Given this list of marker genes Slain2, Rgmb, Chmp4c, Dcaf8, Nckap5, Tfb2m, Fbxo28, Pcsk5, Fyco1, Zbtb9, Trpv6, Plekha3, Tmem123, Foxj3, Tppp, Crybg3, Rb1cc1, Zdhhc8, Xrn1, Dock4, Nedd4l, Wdfy3, 2510009E07Rik, Zfp827, Rap2c, St8sia2, Rasgrf2 (NCBI Gene Id 70739), Unc80, Bahd1, Creb1, Cfl2, Fat2, Vash2, Mkrn1, Fnbp1l, Prr14l, Frmd6, Akt3, Dennd10, Tph1, Srcin1, Rgma (NCBI Gene Id 244058), Sall3, Cmpk1, Slc18a2, Cald1, Lrp8, Armc8, Camk2n2, Dcbld2, Cast, Rundc1, Irf9, Fam117b, Strip2, C2cd2, Ago1, Ptpn3, Zbtb18, Lima1, Phip, Kif23, Tanc2, Cnot7, Zfp236, Ano5, Ezh1, Fastk, Laptm4a, Trim36, Cnot6l, Elk3, Rb1 (RB transcriptional corepressor 1), Crk, F3, Usp46, Mcl1, Kcnb1, Rab12, Mylip, Rhoc, Mosmo, Neurog2 (neurogenin 2), Napepld, Tnks1bp1, Mtmr3, Pgm2l1, Stk11, Pkd2l2, Scn1a, Celsr2, Igsf10, Rnf128, Mospd2, Pde3b, Afg1l, Prrg1, Bnip2, Slc40a1, Hook3, Olfm1, Heg1 (NCBI Gene Id 77446), Wfs1, Gab1, Cc2d1a, Creb5, Snx16, Ldlrap1, Sos1, Kdm2a, Septin2, Aak1, Lypd6, Purb, Sobp, Pfkp, Map3k12, Npat, Gpc6, Neurog3, Tmcc3, Il25 (NCBI Gene Id 140806), Zhx2, Pcdha11, Rcan3, M6pr, Usp24, Pdcd1lg2, Eri1, Rab11fip5, Abcg4, E2f1, Pcdha10, Pdgfra, Cdca7, Ssh2, Fzd3, Sybu, Atl3, Cd69, Rasl11b, Gbf1, Atad2, Mfn2 (NCBI Gene Id 170731), Tle4, Mmp24, Rgs17, Rnf150, Klhl28, Vldlr, Arhgap26, Sema4b, Zc3h12c, Osm, Pcdha12, Slc6a9, Fcho2, Zbtb4, Rock2, Ogfod2, Slc17a8, Has2, Fam219b, Nagk, Rab22a, Uri1, Pitpna, Kif3b, Spopl, Cdc37l1, Agfg2, Rab10 (RAB10, member RAS oncogene family), Pcdha7, Socs6, Rapgefl1, Fbxo21, Pgbd5, Kmt2b, Tbc1d12, Rab5b, Snx8, Gramd1a, Tasor, Timp2, Wasf1, Fndc3b, Ahrr (aryl-hydrocarbon receptor repressor), Srgap1, Arhgap35, Zdhhc1, Med12l, Mink1, Retreg3, Rp2, Luzp1, Nbea, Gxylt1, D030056L22Rik (NCBI Gene Id 277265), Lrch1, Nr4a3, Klf9, Psd, Ndel1, Ano3, Idua, Pcdha3, Ankib1, Clock (clock circadian regulator), Pcdha9, Abhd5, Gid4, Unkl, Zfp148, Midn, Pxk, Nabp1, Tspan9, Pls1, Pnpla1, Pcdha4, Bnc2, Txnip, Slc49a4, Trappc14 (NCBI Gene Id 231807), Arhgef10, Atg14, Slc2a4, St6galnac3, Atxn1l, Dab2, Rps6ka4, Sorl1, Nr2c2 (nuclear receptor subfamily 2, group C, member 2), Tsg101, S1pr1, Zfp91, Chd9, Mapk4, Arhgap12, Pcdha2 (NCBI Gene Id 353234), Mfap3l, Csnk1g1, Pkd1, Arhgef11, Sfmbt1, Glis3, Rnf2, Dusp2, Lrrc55, Col4a4, Cep57, Slc17a7 (NCBI Gene Id 72961), Tgfbr2, Trappc2, Vangl1, Col19a1 (collagen, type XIX, alpha 1), Ddhd2, Lhx6, Dpysl2, Tnfrsf21, Topors, Zfand4, Map7, Myt1l (NCBI Gene Id 73066), Pcdha5, Csrnp3, Ptchd4, Pcdhac2, Slc24a2, Fbxl5, Rps6ka5, Dnal1, Sall1 (spalt like transcription factor 1), Ahnak, Marchf8, Tafa1, Ankrd17, U2surp (U2 snRNP-associated SURP domain containing), Nek9, Rest, Abca1, Jpt1, Kpna2, Usp32, Dsg4, Tmem64, Map3k13, Acer2, Mex3d, Kat2b, Pcdha8, Mier1, Kcnk10, Sash1, Bbx, Iqsec2, Apcdd1, Klf11, Trip10, Camta1, Pcdha1, Dgkq, Rs1, Ulk1, Ankrd33b, Slc25a40 (NCBI Gene Id 319653), Slc16a9, Zfyve26, Bmpr2, E2f5, Aktip, Plxdc2, Nup35, Tet1, Kif5a, Slc31a2, Zfpm2, Smad5, Slc16a6, Jazf1, Spred1, Myo1d, Arid4b, Sh3bp2, Pex5l, Chrm2, Tmem267, Lratd2, Nfat5, Dnajc24, Bcl2l11, Npas3, Tbc1d8b (NCBI Gene Id 75757), Naa30 (N(alpha)-acetyltransferase 30, NatC catalytic subunit), Znfx1, Bcl11b, Ncoa3, Dpysl5, Pthlh, Fibin, Hs3st5, Tars2, Cep120, Dennd5b, Zfp661, Btbd10, Lama3, Ism2, Fgd5 (FYVE, RhoGEF and PH domain containing 5), Prr15, Rab33b, Epha7, Uevld, Frs2, Smoc2, Brms1l, Unk, Fam13c, Rsbn1, Ube2q2, Susd6, Mastl, Fjx1, Rbl2, Sertad2, Pkd2, Smoc1, Sumf1, Ntng1, Pcdhac1, Gpr137c, B3galt2, Acsl4, Trip11, Tnks2, Slc25a36, Stx6, Gabbr2, Tbc1d9 (TBC1 domain family, member 9), Lpgat1 (NCBI Gene Id 98667), Fgd4, Fat4, Stk38, St6galnac6, Rbbp7 (retinoblastoma binding protein 7, chromatin remodeling factor), Mknk2, Ankrd9, Npas2, Ptpn21, Ythdf3, Rps6ka1, Ppp1r21, Mier2, Tnfaip1, Zfp800, Zfp704, Tmem127, Hlf (hepatic leukemia factor), Fsd1l, Atg16l1, Itgb8 (integrin beta 8), Hbp1, Slc12a7, Panx2, Oxr1, Bicd2, Slc22a23, Fbxo31, Rasd1, Pcdha6, Rsrp1 (NCBI Gene Id 72409), Adam9, Smim5, Ppp1r15b, Suco, Mapre3, Zbtb41, Ppp1r3b, Gon4l, Sqstm1, Kcnq2, Arhgap1, Pkn2, Crot (NCBI Gene Id 74114), App, Gnb5, Ficd, Nanos1, Ptpn4, Eif4a2, 6430548M08Rik, Zfp512b, Col4a3, Tmed8, Rab3gap1, Zfp367, Osr1, Pafah1b1, Rufy2, Sh3pxd2a, Derl2, Ankrd13c, Ddhd1, Pak5 (NCBI Gene Id 73084), Irf2bp2, Flt1, Rab8b, Srpk2, Ginm1, Ugdh, Ankrd52, Ss18l1, Ube3c, Pbx3, Foxj2, Tiam1, St3gal1, P2rx4, Map3k8, Myf5, Kmt2a, Ints14, Ccng2, Hycc2, Stxbp5, Mapre1, Dmtf1, Rnf6, Coro2b, Limk1, Btg3, Wdr37, Rassf2, Tbcel, Reps2, Cep97, Akap13, Ccdc71l, Polr3g, Prepl, Smyd1, Egln3, Enpp5, Map3k14, Ormdl3, Sema7a, Epha4, Gpr137b, Camta2, Map3k2, Trim3, Retreg2, Map3k9, Sar1b, Usp3, Reep3, Ppp1r3e, Map6d1, Gad2, Cbln4, Zfp9, Atxn7l1, Gosr1, Skor1, Nrip3, Rab30, Arhgef18, 1600012H06Rik, Plekha7, Golga1, Itpripl2, Gpr63 (G protein-coupled receptor 63), Clip4, here is a description of the gene set: Mouse Gene Set: MIR_106B_5P studied in species Mus musculus from publication Chen Y, Wang X (PMID 31504780) Genes predicted to be targets of miRBase v22 microRNA mmu_miR_106b_5p in miRDB v6.0 with MirTarget v4 prediction scores > 80 (high confidence targets).